The following is a description of a gene set: The process in which the S-shaped body is generated and organized. The S-shaped body is the successor of the comma-shaped body that contributes to the morphogenesis of the nephron. Human Gene Set: GOBP_S_SHAPED_BODY_MORPHOGENESIS studied in species Homo sapiens, and this is the list of marker genes: PKD2, PAX8, LHX1, HES5, WT1, BMP4 (NCBI Gene Id 652), HES1